Given this list of marker genes PYCARD, MEFV, CARD9, IL17F, ZFPM1, MYD88, EIF2AK2, SYK, ERBIN, AIRE, OAS1, EPHA2, APOD, LILRB4, IL1B, ADIPOQ, MIR766, CSF1R, IL1RL1, DEFB131A, IL33 (NCBI Gene Id 90865), HMOX1, MUL1, MIR146A, MIR17, ADORA2B, SIGIRR, HAVCR2, SELENOK, LGALS9, TRIM32, SOCS5, IL17A, HMGB1, IL10, TGFB1, KLF4, MIF, IFNG, WNT5A, IL6, IL7, TLR9, DEFB124, OAS3, EGR1, IL6R, MIR590, ADCYAP1, C5, DDX3X, FOXP1, APP, CXCL6, LBP, TSLP, RIPK2, ACKR1, SNAI2, GSTP1, TICAM2, MIR34A, FFAR2, MIR214, C1QTNF3, IL17RA, TWIST1, TLR7, F2RL1, CD74, POSTN, MBP, TLR3, TRPV4, ARG2 (NCBI Gene Id 384), AIF1, MAVS, CHIA, HIF1A, MCOLN2, NR1H4, MIR92A1, AGER, ALOX15B, AZU1 (NCBI Gene Id 566), MIR106A, TNF, ADAM17, IL18, MIR140, TICAM1, CLEC7A, ELANE, IL4R, TLR2, MIR26B, TLR4, LPL, TNFSF4, MAP2K5, TIRAP, TREM2, FFAR3, SIRPA, here is a description of the gene set: Human Gene Set: GOBP_CHEMOKINE_PRODUCTION studied in species Homo sapiens The appearance of a chemokine due to biosynthesis or secretion following a cellular stimulus, resulting in an increase in its intracellular or extracellular levels. All chemokines possess a number of conserved cysteine residues involved in intramolecular disulfide bond formation. Some chemokines are considered pro-inflammatory and can be induced during an immune response to recruit cells of the immune system to a site of infection, while others are considered homeostatic and are involved in controlling the migration of cells during normal processes of tissue maintenance or development. Chemokines are found in all vertebrates, some viruses and some bacteria.